The following is a description of a gene set: species: Homo sapiens Any process that activates or increases the frequency, rate or extent of fertilization. Human Gene Set: GOBP_POSITIVE_REGULATION_OF_FERTILIZATION, and this is the list of marker genes: PRDM9, CCDC87, PRSS37, LHFPL2, CFAP69